Given this list of marker genes UBE2L3, DARS2, UROS, ERBB3, UTRN, PGM2, IL6ST (NCBI Gene Id 3572), CACNB4, CNIH1, CFP, CDK8, MCTS1, RAB3GAP2, RHOBTB1, ZKSCAN5, PON3, CLIC4, PIK3R3, PLCG1, TATDN1, GATB, SLC36A4, ELL3, CYFIP1, NSMAF, ZFYVE28, MINPP1, WASHC3, TKFC, RABL2A, LYSMD2, SLC35B3, MARCKS, TMED6, SLC66A3, CCDC91, BSCL2 (NCBI Gene Id 84753), COQ4, HSP90B1, PTCD3, HRH2, TMBIM1, PLPP7, SEC61B, ABCC1, SPECC1L, DNA2, CRACDL, BCO2, SLC22A3, CYBB, PEX3, DECR1, DSEL, MGA, NUP160, HDDC2, BCKDHB, DDX50, ELK3, ANKZF1, QNG1, TMTC4, MDM4, SLC44A1, FAM149A, CHSY1, GPR39, ATP5PF, BCAP29, CEBPD, AFF1, ZFAND1, SLC66A1, FHIT, ID2, RGMB, PDCD2L, ESPN, CHURC1, SEMA4C, SVIP (NCBI Gene Id 258010), DTNBP1, MRPL37, TMEM26, ELP1, EPS15, LXN, NLRC3, NUDT6, WFS1, TP53, KLHL7, CD81, SLC9A9, NAB1, ETV6, NID1, FGFR1, TAF9B, ODF2L, WDR13, ATXN7, ATG10, GPC5, ACOT13, NDUFB2, RUFY3 (RUN and FYVE domain containing 3), BDH1, TRPS1, LCMT1, UPF3B, MLH1, PLD1, TYROBP, FFAR2, ZMAT3, PTHLH, IL15RA, ATP8A1, TRIM44, SLC39A6, MACO1, CHMP4B, TRAPPC6A (trafficking protein particle complex subunit 6A), TM6SF1, TGM2, TBC1D24, PRXL2A, HAUS3, NFS1, ASCC2, SLC6A13, MAP4K5, TMEFF1, RB1, SMAD6, CERKL, SIRT5, NLRX1, EID2, GOLIM4, NBEA, RNASE4, SPATA13, ITM2B (integral membrane protein 2B), TPD52L1, STX12, HLTF, PECR, CLPP, MCCC2, PRKDC, DUSP22, FBXW10, GGNBP2, RUSF1, REV1, TRUB1, ZNF239, RUNX1T1, RCN1, TGDS, IMMP2L (inner mitochondrial membrane peptidase subunit 2), FRA10AC1, NTPCR, FAM229B, DNMBP, AKR7A2, NUDT7 (nudix hydrolase 7), PPFIBP2, PIM1, COQ2, DCAF7, TMEM100, SYNE1, SRGAP1, E2F6, SLC25A45, PHYHD1 (phytanoyl-CoA dioxygenase domain containing 1), LAIR1, SMARCA2, LGMN, GPM6B, KXD1, CD164, TMLHE, ERN1, TDRD3, SMCO4, MCTP1, MGAM, TUBA8, ZNF706 (zinc finger protein 706), P4HTM, SNX19, CHCHD3, GTF2H2, PPL, MSRB2, here is a description of the gene set: species: Homo sapiens Genes down-regulated in T conv versus T reg FOXP3 knockout. To analyze gene expression in in regulatory T cell precursors that develop in the absence of a functional Foxp3 protein as compared to that of normal regulatory T cells from publication Lin W, Haribhai D, Relland LM, Truong N, Carlson MR, Williams CB, Chatila TA (PMID 17273171) Human Gene Set: GSE6875_TCONV_VS_FOXP3_KO_TREG_DN